The following is a description of a gene set: Human Gene Set: MEF2_04 species: Homo sapiens Genes having at least one occurrence of the motif NNTGTTACTAAAAATAGAAMNN in the regions spanning 4 kb centered on their transcription starting sites. This matches the transcription factor binding site V$MEF2_04 (v7.4 TRANSFAC)., and this is the list of marker genes: DGKI, ZBTB18, SCML1, ADCY2, EYA1, RAP2C, PREP, TRPC4, GJD2, ANP32D, MGST3, NRAP, NFAT5, ELAVL4, RALY, TMEM163, CTHRC1, CYP46A1, CUX1, NR2F1, PRMT3, MACO1, PPARGC1A, LGI1, ASB16, SLCO5A1